The following is a description of a gene set: part of: Diseases of the urea cycle SLC25A15 encodes one of two ornithine-citrulline antitransporters that exchanges cytosolic ornithine for citrulline in the mitochondrial matrix; the second, SLC25A2 is partially functionally redundant. Both transporters play a role in moving substrates required for the urea cycle across the mitochondrial membrane, and consistent with this, mutations in SLC25A15 are associated with the urea cycle disorder hyperornithenemia-hyperammonia-homocitrullinuria (HHH) syndrome. Reactome Pathway: SLC25A15 variants cause hyperornithinemia-hyperammonemia-homocitrullinemia syndrome species: Homo sapiens, and this is the list of marker genes: SLC25A15 (NCBI Gene Id 3089)